The following is a description of a gene set: Human Gene Set: MIR4278 from publication Chen Y, Wang X (PMID 31504780) species: Homo sapiens Genes predicted to be targets of miRBase v22 microRNA hsa-miR-4278 in miRDB v6.0 with MirTarget v4 prediction scores > 80 (high confidence targets)., and this is the list of marker genes: GSTM1, STXBP4, STX17, PTCHD3, ASAH1, SOBP, TFCP2, PRUNE1, TMED2, APOLD1 (NCBI Gene Id 81575), ZSCAN16, GPD1L, MAB21L2, CNTD1, PRELP, GSTM2, TRAPPC10, CLDN1, ATXN1, NUP50, ARCN1, PHLPP1, HJV, VSNL1, POLH, JPH3, TBX10, ZNF395, PRLR, MAN1A2, RLBP1, CD83, NT5DC3, DCLK1, BCL9